The following is a description of a gene set: species: Homo sapiens Human Gene Set: GOMF_GUANYLATE_CYCLASE_REGULATOR_ACTIVITY Modulates the activity of guanylate cyclase., and this is the list of marker genes: GUCA1A, NHERF4, GUCA2B, GUCA1C, NCS1, RCVRN, GUCA2A, GUCA1ANB-GUCA1A, GUCA1B